Given this list of marker genes HMGB1, NFKB1, BECN1, NFE2L2, SHOC2, TFEB, MDM2, TP53, TFE3, STAT3, MITF, MAP1LC3B, ATG7, IPO8 (NCBI Gene Id 10526), PRKN, AGER, KRAS, PINK1, SQSTM1, VMP1 (NCBI Gene Id 81671), here is a description of the gene set: Human Gene Set: WP_AUTOPHAGY_IN_PANCREATIC_DUCTAL_ADENOCARCINOMA Autophagy in pancreatic ductal adenocarcinoma studied in species Homo sapiens